Given this list of marker genes CTRB2, PRSS3, TCN1, LMBRD1, AMN, CBLIF, CTRB1, ABCD4, PRSS1, CUBN, here is a description of the gene set: Human Gene Set: REACTOME_UPTAKE_OF_DIETARY_COBALAMINS_INTO_ENTEROCYTES Uptake of dietary cobalamins into enterocytes species: Homo sapiens